Given this list of marker genes Celf4, Slc35f1, Zfp951, Plppr4, Nagk, Ces2e, Malt1, Mycbp, Igf2, Negr1, Ppm1l, Stxbp6, Camk2d, Agfg1, Irs4 (NCBI Gene Id 16370), Adcyap1, Adamts5, Gnb4, Acvr2b, Il7, Sptbn1, Cyp2c55, Ano3, Or8g20, Zfp970, Rab7, Gm6712 (NCBI Gene Id 100862203), Syt15, Kcnmb2, EU599041 (expressed sequence EU599041), Rora, Milr1, Rock2, Ten1, Vps37a, Zng1, Gpc6, Spry2, Ptbp3, Fut9, Zfand3 (zinc finger, AN1-type domain 3), Ifit2, Sgk3, Rab32, Amotl1, 2210418O10Rik, D630023F18Rik, Zfp1009, Bud13, Gabrg1, Evi2a, Foxk1, Ccdc89, Arrdc3, Zfp97, Rdh9, Eif4g3, Sema5a, Eif4h, Zfp931, Gm14296, Ankrd29, Rslcan18, Phka1, Rhot1, P2ry1, Dact1, Tmem52b, Ccnc (cyclin C), Enpp6, Cplx2, Nr4a1, Yaf2, Zfp1008, Relch, Zfp971, Psma4, Tcf4, Pcsk2, Zfp120, Lamtor5, Zfp976, Trpc6, Tnfaip8 (NCBI Gene Id 106869), Zfand4, Pthlh (NCBI Gene Id 19227), Zfp935, Car10, Chml, Dach2, Fech, Kics2, Kcnv1 (potassium channel, subfamily V, member 1), Aqp4, Zswim2, Nox4, Zdhhc20, Gng12, Zfp966, En2, Mab21l2, Zfp967, Ndufaf7, Gm9 (predicted gene 9), Strbp, Kpna1, Nap1l4, Npy6r, Treml2, Kcne4, Tmem196, Zfp830, Zfp960, Rmdn1, Pdzrn4, Ugt2b36, Hexim1, Zfp936, Gabrb3, Tsc22d2, Onecut3, Rdh16, Taf2, Gabra2, Sema3a, Shank2, here is a description of the gene set: studied in species Mus musculus Genes predicted to be targets of miRBase v22 microRNA mmu_miR_1198_5p in miRDB v6.0 with MirTarget v4 prediction scores > 80 (high confidence targets). Mouse Gene Set: MIR_1198_5P from publication Chen Y, Wang X (PMID 31504780)